The following is a description of a gene set: from publication Mikkelsen TS, Hanna J, Zhang X, Ku M, Wernig M, Schorderet P, Bernstein BE, Jaenisch R, Lander ES, Meissner A (PMID 18509334) Somatic cells can be reprogrammed to a pluripotent state through the ectopic expression of defined transcription factors. Understanding the mechanism and kinetics of this transformation may shed light on the nature of developmental potency and suggest strategies with improved efficiency or safety. Here we report an integrative genomic analysis of reprogramming of mouse fibroblasts and B lymphocytes. Lineage-committed cells show a complex response to the ectopic expression involving induction of genes downstream of individual reprogramming factors. Fully reprogrammed cells show gene expression and epigenetic states that are highly similar to embryonic stem cells. In contrast, stable partially reprogrammed cell lines show reactivation of a distinctive subset of stem-cell-related genes, incomplete repression of lineage-specifying transcription factors, and DNA hypermethylation at pluripotency-related loci. These observations suggest that some cells may become trapped in partially reprogrammed states owing to incomplete repression of transcription factors, and that DNA de-methylation is an inefficient step in the transition to pluripotency. We demonstrate that RNA inhibition of transcription factors can facilitate reprogramming, and that treatment with DNA methyltransferase inhibitors can improve the overall efficiency of the reprogramming process. Genes with intermediate-CpG-density promoters (ICP) bearing the tri-methylation mark at H3K27 (H3K27me3) in MEF cells (embryonic fibroblasts). Mouse Gene Set: MIKKELSEN_MEF_ICP_WITH_H3K27ME3 species: Mus musculus, and this is the list of marker genes: Ahsg, Mybpc2, Epn3, Cd40, Gdap1l1 (ganglioside-induced differentiation-associated protein 1-like 1), Lefty1, Spaca7, Exph5, 1700012B09Rik, Avpr1b, Zdhhc22, 2300002M23Rik, Kcnj9 (potassium inwardly-rectifying channel, subfamily J, member 9), Scn9a, Lpo, Bicdl2, Tmem63c (NCBI Gene Id 217733), Aqp6, Noxa1, Kcnn3, Hepacam2 (NCBI Gene Id 209089), Dlg2, Tbx22, Hesx1, Fgr, Guca1a, Epcip, Tnfrsf13c, Alox12e, 1700020L24Rik, Gfi1b, Nrsn2, Tbata, Egf, Gas2l2, Car14, Wfdc10, Nr5a1, Nme8, Kcnk10, Slitrk1, Chdh, Chrng, Bsx, Prr19, Mtcl3, Ly6g6c, Cutal, Spint4, Upk2, Cldn9, Art3, Atcay, Ciita, Sult2b1, Lrrc4b, Mogat1, Npy4r, Tnf, Tjp3, Akp3, Pde11a, Prss36, Zfp663, Ren1, Pou2f2, Hc, Plcxd3, Sez6l2, Kcnd2, Slc38a5, Lrrc23, Nsg2, Slc25a41, Trim15, Espn, Ano4, Lrrc43, Zic4, Car3, Abcc3, H2-T3, Grb7, Grm3, Hoxb13, Tmem181b-ps, Nkx2-6, Adamts16, Cd72, Klb, Or2b11, Stra6l, Tcam1, Aqp2, Cdh12, Tnk1, Pvalb, Slfn5, Erich5, Pde1c, Slc9a4, Alox8, Ckmt1, Rgs8, Thsd4, Arhgap9, Pamr1, Sox17, Dkk1, Pcdh12, Nfe2, C1qa, Qprt, Vrtn, Tfap2b, Col4a3, Nphs1, Pdyn, Cux2, Tmem184a, Fam149a, Kcnip2, Mst1, Cfc1, Lingo4, Islr2, Rln1, Cfap95, Pnma8a, Tmem232, Cfap65, Ffar3, Etv2, Lta, Smtnl1, Entpd3, Sybu, Kcnmb2, Kcnj5, Slc38a11, Slc28a3, Phyhip, Vtn, Ly6g6e, Wnt8b, Odad1, Tmem45b, Upk3a, Gnat1, Pax5, Miox, Hoxb3, Mc1r (melanocortin 1 receptor), Nccrp1, Nrg4 (neuregulin 4), Mrgprh (NCBI Gene Id 80978), Noto, Resp18, Galntl6, Pik3cd, Chrnb4, Elmo1, Scn1a, Pde8b, Nr5a2, Col4a4, Phactr1, Spata3, Cripto, Epo, Ttll6, Lrrc36, Tymp, Nrl, Fxyd7, Tnfrsf8, Dnajb13, Adgrg7, Faim2, Brinp3, Ncan, Pm20d1, Prss16, Mall, Ryr1 (NCBI Gene Id 20190), Gipr, Gpr84, 2410137M14Rik, Cyp1a2, Cd3d (NCBI Gene Id 12500), Kcng4, Esrp1, Cplx3, Rasgrp4, AI593442, Npvf, Tlr12, Olah, Ucp1, Apoa4, Hjv, Ankmy1, Pnoc, Slc24a1, Arid3b, Calcb, Tdrd1, Rtbdn, Cntnap4, Mef2b, Syt3, Pkhd1l1